Given this list of marker genes ITGA2, RNU7-1, RNASEH2C, ITGA2B, SAMHD1, RNASEH2B, GP1BA, GP1BB, RNASEH2A, ITGB3, CD109, LSM11, TREX1, IFIH1 (NCBI Gene Id 64135), ADAR, here is a description of the gene set: Low platelet count associated with maternal platelet-specific alloantibodies. Human Gene Set: HP_NEONATAL_ALLOIMMUNE_THROMBOCYTOPENIA studied in species Homo sapiens Neonatal alloimmune thrombocytopenia